The following is a description of a gene set: studied in species Mus musculus Mouse Gene Set: GOMF_ACETYLTRANSFERASE_ACTIVATOR_ACTIVITY Binds to and increases the activity of an acetyltransferase, an enzyme which catalyzes the transfer of an acetyl group to an acceptor molecule., and this is the list of marker genes: Naa16, Pdcd5, Brpf1, Serinc5, Serinc1, Pdcd5-ps, Nupr1, Naa15 (NCBI Gene Id 74838), Naa25, Bcas3